Given this list of marker genes ENSG00000221245, METTL14-DT, METTL14, RNU1-138P, RPF2P2, MRPL42P1, C4orf3, LINC02262, ENSG00000293005, CUL4AP1, KRT18P21, USP53, SEPTIN14P4, PGAM4P2, EIF3KP3, RNU6-119P, MIR1973 (NCBI Gene Id 100302290, microRNA 1973), LINC02264, NDUFS5P5, FABP2, PDE5A, ENSG00000301001, MYOZ2, CEP170P1, ARSJ, LINC01378, ACTN4P1, TRMT112P1, UGT8 (UDP glycosyltransferase 8), RPSAP35, ENSG00000310222, LINC01365, TRAM1L1 (translocation associated membrane protein 1 like 1), SEPTIN7P14, RNU6-1217P, CICP16, NDST4, SEC24D, NT5C3AP1, TTC39CP1, GTF2IP12, SNORA24, SYNPO2, NDST3, FKBP4P1, PRSS12, RN7SL808P, RNU6-1054P, CAMK2D, SNHG8, MIR577, RNU4-33P, KLHL2P1, MRPS33P3, CIR1P2, RN7SL184P, ENSG00000288781, here is a description of the gene set: studied in species Homo sapiens Human Gene Set: chr4q26